Given this list of marker genes NCF1, NKX3-1, FOXP1, NASP, XRN1, ROCK2, HMGCS2 (NCBI Gene Id 3158), NCOA4, AVP, SRD5A2, SRD5A1, SIRT1, GBA1, DUSP1, RWDD1, HOXB13, HOXA13, MTAP, HSF1, CFLAR, HOXA9, EDN1, CA9, BGLAP, AARD, SLC39A9, ELK1, TSPO, EPO, GPI, PSPH, CAD, MSTN, CALR, GNRH1, PLN, SPP1, HOXA11, THBS1, AR, HOXA10, CBL, MSN, TBXA2R, HOXD13, here is a description of the gene set: Human Gene Set: GOBP_RESPONSE_TO_TESTOSTERONE species: Homo sapiens Any process that results in a change in state or activity of a cell or an organism (in terms of movement, secretion, enzyme production, gene expression, etc.) as a result of a testosterone stimulus.